The following is a description of a gene set: species: Mus musculus Any process that modulates the frequency, rate or extent of endodermal cell differentiation. Mouse Gene Set: GOBP_REGULATION_OF_ENDODERMAL_CELL_DIFFERENTIATION, and this is the list of marker genes: Mesp1, Nanog, Col5a2, Sox17, Map2k1, Col5a1, Macroh2a1, Dkk1